Given this list of marker genes Cog4, Uvrag, Arf3, Stx5a, Sec22b (SEC22 homolog B, vesicle trafficking protein), Bicd2, Copz1, Nbas, Copz2, Cope (coatomer protein complex, subunit epsilon), Bnip1, Kdelr3, Cog3, Atp9a, Use1, Kdelr2, Lman2, Htt, Tmem115, Rab6a, Arf5, Pitpnb, Rab33b, Golph3l, Kif1c, Ergic3, Stx18, Kdelr1, Rer1 (retention in endoplasmic reticulum sorting receptor 1), Rab6b, Golph3, Arf4, Ergic1, Gbf1, Scyl1, Scfd1, Plpp3, Ergic2, Arcn1, Atp9b, Tmed10, Cog7, Bet1l, Copa, Copb2, Rint1, here is a description of the gene set: The directed movement of substances from the Golgi back to the endoplasmic reticulum, mediated by vesicles bearing specific protein coats such as COPI or COG. Mouse Gene Set: GOBP_RETROGRADE_VESICLE_MEDIATED_TRANSPORT_GOLGI_TO_ENDOPLASMIC_RETICULUM species: Mus musculus